The following is a description of a gene set: Any structural anomaly of the muscular columns which project from the inner surface of the right and left ventricles of the heart (cardiac trabeculae, trabeculae carneae). Abnormal morphology of myocardial trabeculae studied in species Homo sapiens Human Gene Set: HP_ABNORMAL_MORPHOLOGY_OF_MYOCARDIAL_TRABECULAE, and this is the list of marker genes: ACTC1, SDHD, TNNT2, VARS2, ACTN2, CALM2, LDB3, SDHA, SCN5A, NPPA, DTNA, MIPEP, MYBPC3, JUP, MIB1, COA6, NONO, HCN4, MYH7, PRDM16